Given this list of marker genes Lmod2, Dmpk, Smo, Rarb, Ift20, T, Nkx2-6, Map2k4, Daxx, Tnnt3, Mylk3, Xk, Efnb2, Cfl2, Sirt6 (NCBI Gene Id 72769), Mesp1, Hdac5, Dmd, Rcan1, Rbpj, Ankrd2, Nek5, Frs2, Norad, Ddx39b, Myom3, Bves, Spg11 (SPG11, spatacsin vesicle trafficking associated), Tmem182, Nebl, Myl2, Ezh2, Sik1, Cntnap2 (contactin associated protein-like 2), Slc8a1, Hamp2, Alpk3, Tbx5, Pgm5, Myocd, Myorg, Bmp4, Casq1, Trim72, Myf6, Hottip, Acvr1, Myom1, Ldb3, Piezo1, Adra1a, 3425401B19Rik, Slc9a1, Trip10 (thyroid hormone receptor interactor 10), Igf1, Ins2, Six1, Tmod2, Ryr1, Pdlim5, Mmp14, Synb, Fhl2, Morf4l2, Hdac4, Prkar1a, Rxrb, Nphs1, Krt8, Capn3, Cyp26b1, Krt19 (keratin 19), Mapk14, Zfp418, Smyd3, Neu2, Rgs4, Tnnt2, Yy1, Myl9, Akt1, Dock2 (dedicator of cyto-kinesis 2), Foxp1, Msx1, Mfn2 (mitofusin 2), Actn2, Mymx, Lmod3, Speg, Ccn4, Tsc1, Nrg1, Casp1, Ppif, Flii, Csrp2, Spag9, Kel, Klf5, Fktn, Wt1, Ccl8, Bmp2, Ttn, Hdac9, Bcl9, Plpp7, Wnt10b, Dyrk1a, Ski, Casq2, Atg7, Cntnap1 (contactin associated protein-like 1), Stac3, Pin1rt1, Ehd2, Mybpc3, Slc25a4, Col14a1, Actn3, Adgrb1, Wdr1, Maml1, Parp2, Bmp10, Adamts5, Ankrd23, Isl1, Ppara, Fzd7, Klhl40, Alpk2, Sdc1 (syndecan 1), Ccnd2, Irx3, Prkg1, Mypn, Ep300, Adrb1, Tbx3, Tmod3, Asb2, G6pd2, Trim32, Prkd1, Agt, Tbx18, Rgs2, Sort1, Myhas, Cdon, Pdgfrb, Kras, Ccn3, Myh9, Igfn1 (NCBI Gene Id 226438), Cxcl9, Fdps, Cd53, Nfatc2, Ehd1, Synpo2l, Ppp3cb, Mtpn, Ybx1, Shox2, Notch1, Igf2, Nrap (nebulin-related anchoring protein), Bcl2, Dyrk1b, Ppp3ca, Rbm24, Cacybp, Tcap, Myoz1, Pak1, Neb, Smad4, Cxcl12, Rbm10, Pmp22, Edn1, Capn2, Six4, Lrrc10, Cxadr, Il4, Col6a1, Homer1, Dicer1, Tbx1, Cxcl10, Ift88, Atp11a, Sgcb, Il36g, Pi16, Tgfb1, Greb1l, Nln, Calr, Bmpr1a, Mir351, Casp7, Rara, Kdm6b, Nr3c1, Ang2, Bin3, Ptgfrn, Epc1, Lmod1, Itgb1, Myh6, Csrp3, P2rx2, Rpl3l, Hamp, Gdf15, Acta1, Dock1, Mtor, Prox1, Tnnt1, Gata4, Cripto, Plekho1, Sirt1, Agtr2, Neo1, Pin1, Sorbs2, Il4ra, Dner (delta/notch-like EGF repeat containing), Tpm1, Meis1, Nfatc3, Cby1, Scgb3a1, Wnt1, Mir208a, Csrp1, Barx2, Xbp1, Rbm38, Fbxo22, Mybph (NCBI Gene Id 98325), Ntn3, Hand2, Atg5, Myh11, Cdh2, Myc, Arrb2, Grem1, Bvht, Dkk1, Myf5, Selenon, Cacna1s, Rxra, Myod1, Cd81 (CD81 antigen), Pdgfra, Pax3, Met, Akap6, Arid1a, Mybpc1, Camk2d, Plec, Wnt3a, Bhlhe41, Myom2, Xirp1, Dll1, Hey2, Trim63, Rb1, Shh, Hnrnpu (heterogeneous nuclear ribonucleoprotein U), Bdnf, Hopx, Vegfa, Pitx2, Actc1, Ctdp1, Srf, Nox4, Adamts15, Fhod3, Cdk1, Neurl2, Zmpste24, Mef2a, Chuk, Large1, Cd9, Syna, Mef2c, Sox6, Naglu, Hacd1, Tmod4, Cav3, Gsk3b, G6pdx, AW551984, Popdc3, Gata6, Dcaf8, Lncpint, Tanc1, Cflar, Gsk3a, Smyd1, Cav2, Mymk, Hdac2, Tomm70a, Pld3, Mtln, Mamstr (MEF2 activating motif and SAP domain containing transcriptional regulator), Nkx2-5, Hdac3, Flt3l, Bnip2, Igfbp5, Prickle1, Adprhl1, Flnc, Actg1, Casp3, B4galnt2, Popdc2, Myo18b, Mylk2, Tmem119, Kcnj8, Fkrp, Akap13, Tnfsf14, Kat2a, Flot1, Ripor2, Avpr1a, Ctcf, Cavin4 (caveolae associated 4), Dock5, Mybpc2, Adra1b, Csf1r, Bhlha15, Myog, Adgrb3, Stim1, Myh10 (myosin, heavy polypeptide 10, non-muscle), Klhl41, Acadm, Sgcd, Gpx1, Tmod1, Lmna, Myoz2, here is a description of the gene set: The process in which a relatively unspecialized cell acquires specialized features of a striated muscle cell; striated muscle fibers are divided by transverse bands into striations, and cardiac and voluntary muscle are types of striated muscle. Mouse Gene Set: GOBP_STRIATED_MUSCLE_CELL_DIFFERENTIATION species: Mus musculus